Given this list of marker genes CUL2, UBA3, ZYG11B, CBFB, ELOB, RBX1, ELOC, NAE1, here is a description of the gene set: Hijack of ubiquitination by SARS-CoV-2 Human Gene Set: WP_HIJACK_OF_UBIQUITINATION_BY_SARSCOV2 studied in species Homo sapiens